The following is a description of a gene set: Genes having at least one occurrence of the motif ATTAAYTRCAC in the regions spanning 4 kb centered on their transcription starting sites. This matches the ZHX2 transcription factor binding site V$AFP1_Q6 (v7.4 TRANSFAC). Human Gene Set: AFP1_Q6 studied in species Homo sapiens, and this is the list of marker genes: STC1, IL1RAPL1 (interleukin 1 receptor accessory protein like 1), ACVR1B, SFXN2, ITGA11, TMEM178A (NCBI Gene Id 130733), FBLN2, CNTNAP2, CDAN1, IL17C, ARL3, LMO4, PALMD, LRMDA, MSX2, KCNMA1, MAP4, NHLH2, PUM2, MIR9-1HG, FLI1, VAPB, PKP4, ASXL2, TENM3-AS1, TPP1 (NCBI Gene Id 727719), TEX15, MYC (MYC proto-oncogene, bHLH transcription factor), SOAT1, TTC12, DSG4, C11orf52, RBMS1, MYO18A, ADCYAP1, SOX4, ZFHX4 (NCBI Gene Id 79776), LONRF2, SMG1, CITED1, CFB, CDIN1, GPC4, BTG4, EVA1A, CALD1, ANKRD28, HGF (NCBI Gene Id 317720), ELAVL2, USP26, SMC4, HOXD10, DTX3, SPTB, SATB2, MTMR4, CRLS1, ANKS1B, LINC00173 (long intergenic non-protein coding RNA 173), ABLIM1, SIAH3, MYOCD, PLEKHA6, DCX, MLLT11, COL8A1, C6orf62, NIPBL, SPATA7, PHF21A, MMP27, ADAM11, CNPY2, GSX1, CAVIN2, HOATZ, STX7, HAUS4, HOXC6, DTNA, ZIC1, MBD1, ARHGDIB, ZNF202, BRMS1L (BRMS1 like transcriptional repressor), PACSIN3, SIPA1, SCAI, RAB21, FGF12, PCSK2, KCTD15, NOL4L (NCBI Gene Id 63890), LIG3, EPYC, RTN4RL1, FAM78A, SP4 (Sp4 transcription factor), NR2F1, HOXD9, ING4, MCTP2, POLG2, PROX1, MYBPC1, PDZRN4, USP34, DMPK, UTS2, KLF15, MEIS2, ATXN7L1, TECTA, CPN1, CYP26B1, RBFOX2, PCDHGC3, XK, IRF4, BARHL1 (NCBI Gene Id 56751), SESN3, BACE2, SHKBP1, H3-3B, EPHA7, IRX4, MINK1, PMF1, HTR2C, EPB41L3, KIRREL3, EDA, CDH13, FOXP1, ZEB2, DPYD, HOXA1, PLAGL2, AGL (NCBI Gene Id 178), FOXA1, HOXA4, ZMYND8, HOMEZ, ZHX2, ZFPM2, DMRTA1, SRSF8, XPR1, ECEL1, HOXC4, ROGDI, IRX6, SULF1, PDGFRA (NCBI Gene Id 5156), LRFN5, LRRTM3, OTP, TENM1, PRDM13, GPX1, SHOX2, AFF3, PELI2, C1QTNF3, DSCAML1, PART1, JARID2, CNOT2, SPMIP5, KRT84, MYO3B, TBR1, CDC42EP3, BDNF, CCDC174, NDUFB8, BMAL1, RASL10B, BRS3, EFEMP1, WIPI1, GRIN2B, HERPUD2, DNAJC11, DNAJB8, GRHL3, HOXC10, INA, TANK, DLL4, SLC4A4, EPHB2, ZIC4, MAP2K7, ZNF654, HAS2, DLX2, HS3ST5, WNK1, PPM1K, MAP4K4, CREB5, CALCOCO1, LAMC1, CHRDL1, GRPR, RBFOX1, NOG, DVL2, TRERF1, SEC16B, DPYSL3, ZBTB18, SPINK6, JPH3, KIF2B, POFUT1, C11orf24, WNT7A (Wnt family member 7A), ATF3, AARS2, B3GLCT, KIRREL3-AS3, ANKRD39, MRPL48, DUSP6, NR0B2, ID2, BBX, ZNF143, PSMA8, DPYSL2, SIX1, SLC18A2, SEMA3C, SERPINB2, ZNF281, C12orf75, S1PR1, ERG, FOXF2, C2CD5 (NCBI Gene Id 9847), DLX1, TCEAL7, SULF2, TMEM71 (NCBI Gene Id 137835), C3AR1, JAZF1, PHOX2B, PRRX1, ATP6AP2, LAMTOR3, ZNF462, CDC42SE1, NKX2-2, ESR1, KRT85, KCNN3, CTDSPL2, PCBP1, C1orf116, EGFR, ECT2, ZFHX3, HABP2, CACNA2D3, SERTAD4, STEAP1